The following is a description of a gene set: species: Homo sapiens Human Gene Set: WP_MAMMALIAN_DISORDER_OF_SEXUAL_DEVELOPMENT Mammalian disorder of sexual development, and this is the list of marker genes: INSL3, FGF9, EMX2, DMRT1, CBX2, FGFR2, WT1, RBFOX2, SOX9, SRY, MAPK11, GATA4, NR5A1, AMHR2, FOXL2, DHH, PTGDS, PBX1, RSPO1, SRD5A1, SOX8, CTNNB1, WNT4, AMH, FST